Given this list of marker genes Mbd2, Thap7, Gata2, Zxdb, Zxdc, Ebf1, Ehmt1, Pax2, Lef1, Wt1 (NCBI Gene Id 319408), Ehmt2, U2af2, Taf9, Gata1 (GATA binding protein 1, NCBI Gene Id 14460), Srrm2, Hmga2, here is a description of the gene set: Mouse Gene Set: GOMF_C2H2_ZINC_FINGER_DOMAIN_BINDING Binding to a C2H2-type zinc finger domain of a protein. The C2H2 zinc finger is the classical zinc finger domain, in which two conserved cysteines and histidines co-ordinate a zinc ion. studied in species Mus musculus